The following is a description of a gene set: species: Homo sapiens Human Gene Set: HALMOS_CEBPA_TARGETS_UP from publication Halmos B, Bassères DS, Monti S, D'Aló F, Dayaram T, Ferenczi K, Wouters BJ, Huettner CS, Golub TR, Tenen DG (PMID 15205324) Genes up-regulated in H358 cells (lung cancer) by inducible expression of CEBPA off plasmid vector. We showed previously that CCAAT/enhancer binding protein alpha (C/EBP alpha), a tissue-specific transcription factor, is a candidate tumor suppressor in lung cancer. In the present study, we have performed a transcriptional profiling study of C/EBP alpha target genes using an inducible cell line system. This study led to the identification of hepatocyte nuclear factor 3beta (HNF3 beta), a transcription factor known to play a role in airway differentiation, as a downstream target of C/EBP alpha. We found down-regulation of HNF3 beta expression in a large proportion of lung cancer cell lines examined and identified two novel mutants of HNF3 beta, as well as hypermethylation of the HNF3 beta promoter. We also developed a tetracycline-inducible cell line model to study the cellular consequences of HNF3 beta expression. Conditional expression of HNF3 beta led to significant growth reduction, proliferation arrest, apoptosis, and loss of clonogenic ability, suggesting additionally that HNF3 beta is a novel tumor suppressor in lung cancer. This is the first study to show genetic abnormalities of lung-specific differentiation pathways in the development of lung cancer., and this is the list of marker genes: SERPINI1, PLCG1, GLRX, SF3A2, FOXA2, SPDEF, CKAP4, CXCL8, SEMA3C (NCBI Gene Id 222200), ARL4A, SLC30A1, SLC16A7, ETS2, PTGS2, UAP1, RAB27A, NFIL3, PTX3, PTK2B, ADAM3A, CXCL2, BMP2, UGCG, HCAR3, CXCL3, BMP2K, APOC4, IGFBP3, KLF5, FOLR1 (folate receptor alpha), WAS, HMOX1, RGS4, ITGA1, EPHA4, CCL20 (C-C motif chemokine ligand 20), PLIN2 (perilipin 2), BTG1, POU4F1, JAK2, ZNF250, IL1R1, IL4R, TNFAIP8, RAB32, FAS, RGS2, TLX1, MEGF9